Given this list of marker genes B3GALNT2, PANX3, TBL2, SLC27A6, UGT1A5, FLRT2, DERL1, TEX264, RDH16, PDIA5, RNF19B, CYP2C9, SPTLC2, EMC6, ZNRF4, ATP6AP2, POMT1, TMX1, TMCO1, SLC37A3, SYNE3, CHPT1, ULK1, USE1 (unconventional SNARE in the ER 1), RAB21, KLHL41, CYP4V2, SEC23A, HLA-B, RTN2, ALG14 (NCBI Gene Id 199857), BOK, CANX, SRL, UGT2B15, CYP2C8, NBAS, PDCD6, SEC22C, CASQ1, PDZD8, FAM8A1, SEC23B, SAMD8, CYP26C1, PIGW, CYP7B1, PNLDC1, PGAP1, LMAN2L, TMEM68, TMEM151A, HTRA2, P4HTM, TMEM174, PON1, WDR81, COPG2 (NCBI Gene Id 80038), GALNT2 (polypeptide N-acetylgalactosaminyltransferase 2), NAT8, ERO1B, TMBIM4, RDH11, STRIT1, RPS26, CYP3A7 (NCBI Gene Id 1551), IFI27, TKT, SRD5A1 (NCBI Gene Id 6715), CD1D (CD1d molecule), ALG2, ATL2, EMC9, SURF4, JPH1, TMX2, TBXAS1 (thromboxane A synthase 1), BFAR, MTOR, FMO2, ELOVL7, LRRK2, ACSL4, ZDHHC1, RNF144A, NAT8B, PLCD4, MOGAT2, DIPK1C, MINAR2, SLC36A2, HLA-DRB1, SEC22A, RAC3, ANKLE2, EI24, TMEM199, LRIT1, UGT3A2, TMTC2, EIF5AL1, TMCC2, SAR1B, BET1, TMEM33, AQP11 (NCBI Gene Id 282679), AGMO, ESYT3, LPIN1, TMEM147 (transmembrane protein 147), GRIN2C, PHTF1, ATP8B3, PJA2, PLP2, HERPUD1, BECN1, DHRS7, PTPN1, KCNK12, FMN2, RAB1B, PANX1, POMK, HSD11B2, EMC7, TM4SF20, ABCC6, CYB561D2, RCE1 (Ras converting CAAX endopeptidase 1), ATP11C, CNIH3, ELOVL3, FADS3, JPH2, DST, SLC33A1, HHATL, EXT2, MBOAT7, CYP4F22, NOMO1, CTAGE9, SLC16A11, HLA-DRB5, ACSL5, RB1CC1, TMEM63C, TMEM35A, CYB5RL, GIMAP1, HSD3B7, EEF1A2, CERS5, SEC61G, CYBB (NCBI Gene Id 1536), LPCAT4, STING1, PNPLA6, RPN1, SGCG, NOMO2, REEP1, SLC39A7, HAS2, BSG, MAP3K7, STIM2, PGRMC1, LSS, GABARAPL2, LRAT, SLC30A1, SYVN1, SLC8A3, DLG1, CYP4X1, MPDU1, SLC37A1, CYP26A1, GJA1, CYP2U1, NCSTN, AFG2B, CALHM1 (NCBI Gene Id 399807), GPAT4, CDK5RAP3, WLS, SEC11B, GRAMD1C, NFE2L1, DIO2, VTI1B (vesicle transport through interaction with t-SNAREs 1B), SGK1, ERP44, NEU4, CH25H, ATP10A, CDK1, PIGM, SLC22A3, NCEH1, RETREG2, SLC9A6, NOMO3, RNF139, MTDH, MGST2, PREB, ITPR3, PIP4K2B, TMEM97, DDRGK1, VPS13A, OSTC, CYP2D6, RAB2B, CYP2A7, GUCY2C (NCBI Gene Id 2984), SYNE2, TMEM119 (NCBI Gene Id 338773), GPSM1, GPER1, PIGL, FICD, MOGAT1, MX1, RNF125, KRTCAP2, PLA2G4C (phospholipase A2 group IVC), TMED2, HLA-DQA2, CCDC47, NUTF2, FXYD3, SFTPD, SEC24A, ABHD4, SLC27A2, RHOC, SEC24B, CNIH1, DNAJB14, UGT2B28, RAB9A, TRAM2, SLC35A2, MBOAT2, DPY19L4, DPM3, TMX3, SDR16C5, PYURF, ARCN1, TOR1AIP2, EIF5A2, UGT2B10, STIM1, CHRM3, RNF185, TMED6, SLC35D3, POM121C, FMO5, DNAJC18, PON3, SLC27A1, SFTPB, RTN1 (reticulon 1), CYP3A4, KSR1, TMEM39B, OTULINL, CYP2C19, ANO5, TMEM258, TGFA, PIGP, CPT1C, CYB5B (cytochrome b5 type B), CACFD1, SEC16A, ATG9B, SPPL2B, FMO1, SPCS3, LDAF1 (NCBI Gene Id 57366), PLAAT3, DOLK, DDOST, CLIC4, C4orf3, BCAP29, UBIAD1, OST4, UBA52, KCNK2, OTOF, PI4K2B, CYP4F12, SGPL1, PIGS, ALG13, RICTOR, VPS13C, SRI, MOGAT3, CTAGE15, PLAUR, MMP23B, CTAGE8, PIEZO1, RRBP1, TUNAR, CYP2S1, CYP4F11, TLR3, CYB5R3, HM13, KDELR1, PLA2G4A, UBXN7, PRKN, PPP1R15A, CLN6, SEC61A2, PTGS1, SLC35G1, PIGG, LBR, CDIPT, USP17L2, DHRS7B, CERS3, RNF43, MYMX, TMEM109, PTGFRN, ZDHHC12, SIGMAR1, RIC3, TMEM106C, RPE65, HLA-G, CYP2A6, HSD17B12, CYBA, DPM2, RAB5IF, STX18, ERMARD, FITM2, CIDEB, PTGIS, TMEM259, NUS1, KCNA2, DRD1, RINT1, DNAJB9, ALG11, SPINK5, FAAH, MGAT4D, ATP10D, SRP9, BNIP1, TMED4, CNIH4, ADPGK, SARAF, CTDNEP1 (CTD nuclear envelope phosphatase 1), ELOVL2, AUP1, SELENOI, RNFT1, MAGT1, STBD1, CYP2B6, PAPPA-AS1, ESYT1, SLC17A3, TMEM43, BAX, NOTCH3, EXT1, RDH14, PNPT1, SSR3, GORASP2, HMOX2, SUCO, CAV1, RTN3, TMED1, EGFR, GRAMD1B, POFUT2, TMX4, EMC1, RNF5, SREBF1, SGCZ (NCBI Gene Id 137868), STARD3NL, SHISA3, RAC2, KCNK16 (NCBI Gene Id 83795), SGPP2, LTC4S, ZDHHC20, PIGC, KASH5, DDN, ABCB6, MLANA, ITPRIP, SPPL2A, HLA-DRA, NPLOC4, HMOX1, PIGK, SHISA5, CPTP, ABCC12, PIGA, UBXN8, ATG13, TMED5, UGT1A9, SEC61A1, SLC37A4, SRD5A3, TMEM98, SEC24D, ALG6 (ALG6 alpha-1,3-glucosyltransferase), SCAP, SMIM6, MYORG, COPZ1, FATE1, TPTE2, RDH12, YIPF5, AGPAT3 (1-acylglycerol-3-phosphate O-acyltransferase 3), PML, ZW10, FKBP1B, CAMK2B, RAB3GAP2 (RAB3 GTPase activating non-catalytic protein subunit 2), HPD, FLRT3, SHH, EMD, DEGS1, ERMP1, DHDDS, FTCD, SEL1L, INSIG1, CANT1, TAB1, FKBP1A, TMED3, GRIN1, FUT11, ZDHHC4, SEC16B (NCBI Gene Id 89866), NECAB3, WDR83OS, XK, SLC35B1, VCP, ATP11A, ABCB9, ATG101, RNF133, DOLPP1, TAP1, PLA2G2A, UBA5, HSD3B2, VRK2, PLPP7, AWAT1, SPCS2, NR3C2, RHBDD2, STX17, CD74, NOS1, SEL1L2, SERP2, SREBF2, RAC1, HACD2, GRM6, MFSD2A, CYP39A1 (NCBI Gene Id 51302), CDS1, UGT2B4, APOO, TUSC3, ICMT, WFS1, ATP2A1, LMAN1L, TRDN, HLA-DQB1, HLA-A (major histocompatibility complex, class I, A), CYP4F8, DNAJC14, MYRF, UNC93B1, SYNE1, REEP5, MAN1B1, ENTPD2 (NCBI Gene Id 954), FMO3, PARP16, SHISA2, CYP4A22, CHRNA7, LPIN2, FAF1, SQLE, SAYSD1, HLA-DQA1, PSEN2, TMEM132A, PROS1, CFTR, RHOA, VKORC1, SRPRB (NCBI Gene Id 58477), RTN4, IFI6, TLR7, GHRHR, ELOVL6, TESPA1 (NCBI Gene Id 9840), ALDH3A2, TAPBPL, PLOD3, ATL3, TMPRSS3, DGAT1, LMAN1, GRIP1, ATP6AP1, USP19, DNAJC25, RHOG, CYP4F3, TMEM214, ARL6IP5, CKAP4, RNF175, ANKRD13C, ATF6B, STEEP1, CLN8, DUOXA2, JKAMP, HLA-DRB3, DHRS7C, SEC13, SRPRA, REEP4, ALG5, DGAT2, CERS4, UGT1A1, DNAJC1, GSG1, TMEM203, PKD2, DPAGT1, LPIN3, RAB3GAP1, RFT1, YIF1A, CYBC1, PDGFRA, TMEM129, TMEM86A, TMEM50B, ASPH, RAB18, LRRC8B, TMEM53, CYP7A1, TAPT1, SLC10A7, AGPAT1, MLEC (NCBI Gene Id 9761), MOXD1, HSD17B3, DHRS3, CLCN4, LRRC59 (leucine rich repeat containing 59), G6PC1, G6PC3, SVIP, RHBDF1, MSMO1, RPS27A, HSD17B7, CTAGE6 (NCBI Gene Id 340307), UBQLN4, HLA-DPA1, SPCS1, RHEB, PDIA6, IRAG1, CYP51A1, FKBP1C, PCYT2, ACER3, CLSTN2, TMEM178A, UGT1A4, PPM1L, XPO1, SGMS2, CYP4F2, OS9, PLD4 (NCBI Gene Id 414770), LMAN2, RASGRF2, TMEM38A, RPS28, YIPF7, CYB5A, CASP4, YIF1B, CYP1A1, ITPR1, SFTPC, CNEP1R1, NOX4, SGCE, HLA-DRB4, HACD3, SGPP1, RAB6A, SC5D, EMC3, GRIN2D, PTPN5, CHERP, SFTPA1, SLC35B2, PLPP2, ALG12, ATP13A1, SLN, MBTPS1, CYB5R4, SEC22B, LNPK, PAFAH2, PLD3, SSR4, BNIP3, UBC, SLC26A9, ZDHHC6, CASQ2, SLC18A1, TAPBP, RNF26, PITPNM1, SEC31B, FUT10, ZDHHC9, SAR1A, ATL1, TM7SF2, COPB1, CLN3, CERS1, CLSTN3, RANBP2, GDPD1 (NCBI Gene Id 359824), KPNA2, SMIM14, CERS6, CYP4A11, AGPAT2, EXTL1, SLC30A7, TAAR1, VMA21 (NCBI Gene Id 4202), TRIM59, PIGT, LRRC8D, PIGH, NOS1AP, MAP3K5 (NCBI Gene Id 4217), CAMLG, GDPD3, FADS2, IKBIP, PNPLA8, SEC11C, DAD1, CYP3A5, CDC14C, PTDSS2, PIK3R1, RNF121, CALU, PIGY, SLC27A4, RDH5, SMIM30, DISP3, SLC39A1, CYP2A13, ABCA1, HSD17B2, ATP10B, TMC8, CYP46A1, FDFT1, MBOAT4, BLTP1, ORMDL2, DIO1, ATP13A4, EXTL3, CYP2R1, LMBRD1, ZMPSTE24, UGT1A7, CLSTN1, ELOVL4, NCLN, HLA-H, RYR2, GRAMD2A, CLMN, GJC1, KTN1 (kinectin 1), NOTCH1, PLOD2, CSPG5, RP9, SCFD1, CERS2, PGAP3, IFNGR2, SELENOT, UGT1A10, UGT2A1 (NCBI Gene Id 10941), PIGX, ZDHHC14, DNAJB2 (DnaJ heat shock protein family (Hsp40) member B2), ITPR2, DIPK1B, PLN, CYP1B1, TREX1, DNM1L, DHCR24 (NCBI Gene Id 9800), SLC51A, GGCX, MGST1, CREB3L2, NRROS, SRXN1 (NCBI Gene Id 140809), ERGIC1, UGT1A6, GRAMD4, SPAST, NDRG4, ADGRG6, CLPTM1L, FZD9, THADA, ANTXR2, ANXA7, ATXN3, FREY1, ORMDL1, UFL1, NUP210, SEC63, LCLAT1, PEDS1, RTCB, SLC27A3, AMFR, COPB2, AQP8 (aquaporin 8), HMGCLL1, FLVCR2, RDH10, VMP1, HSD11B1, MOSPD2, SLC30A5, SORL1, SBF1, DPM1 (dolichyl-phosphate mannosyltransferase subunit 1, catalytic), ELOVL1, ELOVL5, SOAT1, RYR1, TMCO5A, TMEM38B (NCBI Gene Id 55151), GRIN2A, ABCD1, TMED7, KDELR3, ACSL6 (NCBI Gene Id 56972), MBLAC2, CYP3A43, HLA-F, SEZ6L2, TMEM238L, FMO4, PIGU, ERGIC2, SEZ6L, DPY19L3, SGMS1, AGPAT4 (1-acylglycerol-3-phosphate O-acyltransferase 4), DMPK, MARCHF1, UBXN1, UCHL1, RNF186, REEP3, PTGS2, STT3B, RPL27, CREB3L1, CD59, CTAGE1, TLCD3B, TMEM14A, ZDHHC2, PNPLA2, GUCY2D, ERAP1, ZFYVE27, CYB5R1, UBXN4, AGPAT5, TRPM1, INSIG2, RAB10, SLC39A13, GPAA1, PITPNB, ELAPOR1, CYP2W1, HLA-C, DNAJB12, CAMK2D, CDKAL1, B3GLCT, SGCD, C2CD2L, ATP2A2, NOTCH4, ARMC10, VAMP7, ATP8B2, UGT2B7, TMBIM6, HMGCR, GALNT1, CYP4Z1, HTN1 (histatin 1), DSE, MAPKAP1, ZDHHC22, NOTCH2, PSKH1, IER3IP1, IRGM, VTI1A, TRAM1, OSBPL6, MRAP, ABCG1, MYRFL, FAXDC2, PEX16, PORCN (NCBI Gene Id 65017), GRIN3A, CALR, RSAD2, ILVBL, ERLIN1, GET1, ABHD12B, VAPB, STX5, NSDHL, TLR9, HHAT, UGT2B11, DCSTAMP, MARCHF8, NSG1, DEGS2, HACD1, ALG8, LRIT3, CYP19A1, LRPPRC, GNRH1, SPTSSA, TEX261, PIGB, EMC4, ABHD12 (abhydrolase domain containing 12, lysophospholipase), RPN2, FITM1, ALG10, SLC37A2, SLC35B3, FRRS1L, SSR1, JAGN1, AKAP6, POMGNT2, RHBDF2, LRRC8E, EBPL, ANKS4B, EVA1A, SNCA, ATF6, RPS29 (NCBI Gene Id 6235), CYP4B1, EIF5A, ART1, AREG, JPH4, SLC35D1, EPM2AIP1, ARHGAP32, GOSR2, G6PC2, LPCAT2, VAPA (NCBI Gene Id 9218), MBOAT1, ZDHHC16, RNF145, MGLL, SFTA3, OSBPL5, CYP2J2, GPAT3, JSRP1, ALG3, EMC2, MCTP1, RETREG3, RNF103, PGAP2, ERN2, DNAJA1, SPPL2C, PLPP6, CTAGE4, NAV3, VKORC1L1, PMEL, EMC8, TAP2, UBB, LRBA, PSEN1, TSPO2, DPY19L1, IZUMO1, CAMK2G, TEX2, PIGV, ERGIC3 (ERGIC and golgi 3), BCL2, PCYT1B, SEC24C, RHBDD1, ACSL3, UBE2J2, HACD4, RETSAT, ARV1, BICD2, CYP2F1, FA2H, HSP90B1, BSCL2, ZFYVE1, PIGZ, SPTSSB, HLA-DPB1, SCD, HSD3B1, SEC31A (NCBI Gene Id 51424), PLD1, SPTLC3, RETREG1, CHODL, MOGS, ENO1, SPPL3, UPK3A, EBP (EBP cholestenol delta-isomerase), ATG2A, TBC1D20, CREB3L3, SERINC1, ATG2B, CERT1, CEPT1, ERO1A, ACSL1, AHCYL1, GABBR1, UBE2J1, CYP2E1, CYP21A2, SLMAP, GRIN2B, SDCBP, MRLN, RNF180 (NCBI Gene Id 285671, ring finger protein 180), DHCR7, WASL, ATP2A3, SGCA, FKBP2, SSR2, B3GAT1, MIA3, CD4, CRYZL2P-SEC16B, B2M, OSBPL8, MIA2, FADS1, ATG14, EMC10, PI4KB, ALG1, TMEM41B, ALG10B, PNPLA7, EIF2AK3, CALR3, REEP2, KRAS, SCARA3, PIGO, TMEM170A, SYNE4, DERL3, TMC6, CYP2C18, SLC43A1, NOX5, FLRT1, TRIM13, EPHX1, COPA, XXYLT1, GRAMD1A, PNPLA3, SEC11A, UGT1A8, REEP6, UFD1, STARD3, CYP26B1, CYP1A2, OCA2, TRAPPC2B, STIMATE, SEC61B, TMEM86B, PTCHD3, NAT8L, PEMT, CARD19, TLR8, DHRS4, GHITM, TRPM8, SPTLC1, KLHL14, PSENEN, NAPEPLD, UBAC2, CLGN, SELENOK, ERN1, TTYH1, BCAP31, GRIA1, CYP17A1, MGST3, HLA-E, DGAT2L6, APH1B, TMCC1, DHH, TMT1B, PLOD1, FADS2B, XBP1, DHRS9, SELENON, RNF13, MMGT1, LRRC8C (leucine rich repeat containing 8 VRAC subunit C), COPZ2, SERP1, RAB2A, CLCC1, OSBPL3, ERG28, LPCAT1, CREB3L4, ORMDL3, JPH3, ARL6IP1, LMBR1L, ACER1, ALG9, TYRO3, SLC35B4, LCTL, COPE, HRAS, PIGQ, CDS2, CREB3, COPG1, MR1, SELENOS (NCBI Gene Id 55829), SLC28A3, PLPP3, FOLR1, POM121, DAG1, AGTRAP, CNIH2, MCFD2, AWAT2, AADAC, MOSPD1, DUOXA1, PANX2, UGT2A2, LPGAT1, DIPK1A, ALOX5AP (NCBI Gene Id 241), PLD2, TNPO3, ERLIN2, SORT1, ESYT2, RASGRP1, C8orf17, NRAS, UGT1A3, GUCY2F, SEC62, RAB14, PCYT1A, KDSR, IRAG2, UBA1, MACO1, EXTL2, MARCHF2, LPCAT3, PTGES, KDELR2, DERL2, OSBPL7, TOR1A, PIGF, APH1A, MARCHF5, DNAJC16, GBA2, TMEM260, UGT2B17, ABCD4, SCARB2, RYR3, IL15RA, APOB, CDC42, ATG9A (NCBI Gene Id 79065), SACM1L, DTNBP1, PDIA3, FZD6, TM6SF2, TXNDC11, GET3, GNAI3, SLC27A5, SOAT2, OSBP, RNF183 (NCBI Gene Id 158260), GJB1, TMED9, ZC3H12A, EDEM1, SGCB, ERAP2, STS, FKBP8, IHH, HPN, TMEM94, PKMYT1, PTDSS1, SRD5A2, CYP8B1, P2RX6, RNF170, HLA-DQB2, LMF1 (lipase maturation factor 1), ZDHHC11, MAPK8IP1, TECR, MARCHF6, MRAP2 (NCBI Gene Id 353265), LMF2, POMT2, GPR37, APOL2, HSPA5, TMEM208, TMEM67, PIGN, SMPD4, ILDR2, TRAM1L1, ZFAND2B, SFTPA2, SIK2 (NCBI Gene Id 23235), NUCB2, PTGDS, EDA, UGT3A1, POR, BLTP2, UGT8, TMED10, MEST, SLCO1B3-SLCO1B7, TRAF2, FAF2, TMCC3, SERAC1, EPM2A, STT3A, TRIQK, CYB5R2, FMN1, CISD2, SCD5, TMEM39A, here is a description of the gene set: Human Gene Set: GOCC_NUCLEAR_OUTER_MEMBRANE_ENDOPLASMIC_RETICULUM_MEMBRANE_NETWORK species: Homo sapiens The continuous network of membranes encompassing the nuclear outer membrane and the endoplasmic reticulum membrane.